The following is a description of a gene set: To develop a comprehensive catalogue of phenotypic and functional parameters of human CD4(+) T cell differentiation stages, we have performed microarray gene expression profiling on subpopulations of human thymocytes and circulating naive CD4(+) T cells, including CD3(-)CD4(+)CD8(-) intrathymic T progenitor cells, CD3(int)CD4(+)CD8(+) 'double positive' thymocytes, CD3(high)CD4(+)CD8(-) 'single positive' thymocytes, CD3(+)CD4(+)CD8(-) CD45RA(+)CD62L(+) naive T cells from cord blood and CD3(+)CD4(+)CD8(-) CD45RA(+)CD62L(+) naive T cells from adult blood. These subpopulations were sort-purified to >98% purity and their expressed RNAs were analyzed on Affymetrix Human Genome U133 arrays. Comparison of gene expression signals between these subpopulations and with early passage fetal thymic stromal cultures identify: (i) transcripts that are preferentially expressed in human CD4(+) T cell subpopulations and not in thymic stromal cells; (ii) major shifts in gene expression as progenitor T cells mature into progeny; (iii) preferential expression of transcripts at the progenitor cell stage with plausible relevance to the regulation of expansion and differentiation of these cells; and (iv) preferential expression of potential markers of recent thymic emigrants in naive-phenotype CD4(+) T cells from cord blood. Further evaluation of these findings may lead to a better definition of human thymopoiesis as well as to improved approaches to monitor and to augment the function of this important organ of T cell production. from publication Lee MS, Hanspers K, Barker CS, Korn AP, McCune JM (PMID 15210650) Genes down-regulated at early stages of progenitor T lymphocyte maturation compared to the late stages. Human Gene Set: LEE_EARLY_T_LYMPHOCYTE_DN species: Homo sapiens, and this is the list of marker genes: ANKRD55, STK17A, HCP5, SLC2A3, EMP3, MAP3K1, NELL2, IL6R, COTL1, CD44, CYLD, CYTIP, TNFSF10, CD27, SAMHD1, PRMT2, KLF2, ANK3, SEMA4C, SAMD3, DENND2D, MAN1C1, HLA-F, IFITM2, NFATC2, TNFRSF25, TRABD2A, PIK3IP1, FOXO1, LRRN3, ACTN1, HLA-E, AMIGO2, ATM, HLA-B, BTLA, TUBA4A, IL27RA, TBC1D4, GBP2, S1PR1, HLA-A, GIMAP1, GIMAP7, GPR183, NLRC5 (NCBI Gene Id 84166), IL4R, LDLRAP1, GIMAP4, CCR7, AGMAT, GPR171, IFITM1, ID2, RNASET2, PTPRJ, SCML1